The following is a description of a gene set: Cutaneous abscess Human Gene Set: HP_CUTANEOUS_ABSCESS A circumscribed area of pus or necrotic debris in the skin. species: Homo sapiens, and this is the list of marker genes: DOCK8, IL6ST, NCF2, ZNF341, TGFB1, IKBKB, GJB6, IL10RB, SEC61A1 (NCBI Gene Id 83289), BTK, PSEN1, PGM3, CYBC1, ELF4, IKZF3, IL17RA, UBE2A, IL6R, MAX, OTULIN, CTSC, CARMIL2, MPEG1, G6PC3, GJB2, XIAP, ELANE, LCP2, RIPK1 (NCBI Gene Id 8737), STAT3, MNX1, IL10RA, PSENEN